The following is a description of a gene set: Any process that results in a change in state or activity of a cell (in terms of movement, secretion, enzyme production, gene expression, etc.) as a result of a cisplatin stimulus. species: Mus musculus Mouse Gene Set: GOBP_CELLULAR_RESPONSE_TO_CISPLATIN, and this is the list of marker genes: Rad51, Ddx11, Timeless, Hmox1, Slc31a1